Given this list of marker genes SEMA4D, ACP5, PTGER4, LTBP3, SOX9, FBN1, OPA3, RUNX2, CHSY1, SLC9B2, PRPSAP2, EXT1, SLC38A10, TP53, SKI, RARA, LARGE1, RARB, TRIM45, GHR, AMER1, PDGFA (platelet derived growth factor subunit A), MEF2C, NOTUM, GH1, SH3PXD2B, PEX7, IFITM5, STC1, TIFAB, MEGF8, COL6A1, BGLAP, GHRL, COL1A1, P2RX5, PLS3, OGN, LOX, ITGB6, MMP14, IHH, PPIB, OSTN, PITX2, LILRB1, FOXC1, GLG1, RFLNA, PAPPA2, SMPD3, RFLNB, SLC10A7, RARG, GREM1, TYROBP, DYM, ATP6AP1, CCN4, DCHS1, RYR1, IFT80, RANBP3L (NCBI Gene Id 202151), SMAD5, HSD17B1, CTC1, BMP6, EVC, LEPR, TGFB1, TTC9, NOTCH2, POC1A, VKORC1, NAB1, CLDN18 (NCBI Gene Id 51208), INSIG2, TMEM38B, MYOC, FBLN5, DDR2, CDX1, TMEM107, FOXN3, XYLT1, TGFBR2, PTH, AXIN2, SULF2, HOXA11, FOXP1, CITED2, COL3A1, LTF, ATG9A, TWIST1, GJA1, ASXL1 (NCBI Gene Id 23393), TAPT1, TMEM119, TRPV4, LIPA, GNAS, SFRP4, FGFR3, LRP5, COMP, KDR, PHEX, SRD5A1, GPR68, IGF1, OSR2, BPNT2, TRIP11, PTPRC, CHAD, LRRC17, EPYC, RPL13, PDGFC, TNFSF11, SNX10, GALNT3, NPPC, SCX, MSX1, CCDC154, LRRK1, DLX5, POR, MBTPS2, KAT2A, NAB2, BBX, SBDS, FGFR2, COL13A1, SPNS2, FREM1, FOSL2, INPPL1, INSIG1, WNT1, GGCX, DCANP1, FGF18, MMP16, NEUROG1, MCPH1 (microcephalin 1), COL27A1, ZMPSTE24, GLI3 (NCBI Gene Id 2737), MAPK11, BMP4, P3H1, EBP, TSKU, MMP13, RIPPLY2, DHRS3, SRC, IFT172, ADAMTS12, BNC2, ENSG00000274276, AKAP13, COL2A1, MATN1, ADAMTS7, SMAD1, ECM1, ZBTB16, THBS3, CYP26B1, SP5, ALPL, BGN, NSD2, BMPR1B, ANXA2, FBXW7, ACTN3, SIGLEC15, PHOSPHO1, HOXB4, RAB23, MSX2, SRD5A2, MAP2K6, MIGA2, CBS, TNN, OPTC, SHOX2, FAM20C, PLXNB1, SULF1, FGF4, CSGALNACT1, BBLN, TGM2, EXT2, BMP2, TULP3, ATG9B, CER1, RHOA, PAFAH1B1, FGF8, SERPINH1, HAS2 (NCBI Gene Id 3037), ATF2, BMPR2, TFAP2A, LEP, MAPK14, NPR2, here is a description of the gene set: Human Gene Set: GOBP_BONE_DEVELOPMENT species: Homo sapiens The process whose specific outcome is the progression of bone over time, from its formation to the mature structure. Bone is the hard skeletal connective tissue consisting of both mineral and cellular components.